Given this list of marker genes NPNT, HIPK2, AXIN1, MIR21, FLCN, GOT1, CITED2, RNF111 (NCBI Gene Id 54778), CITED1, GIPC1, CDKN1C, CDKN2B, ING2, TSC22D1, TGFBR3, FERMT1, ADISSP (NCBI Gene Id 54976), HSP90AB1, EP300, ZEB2, CREBBP, SLC2A10, ITGA8, LRG1, SNW1, STK11, SMAD4, MIR30B, MEN1, THBS1, TWSG1, TGFB1I1, MYOCD, SDCBP, here is a description of the gene set: Any process that activates or increases the frequency, rate or extent of cellular response to transforming growth factor beta stimulus. Human Gene Set: GOBP_POSITIVE_REGULATION_OF_CELLULAR_RESPONSE_TO_TRANSFORMING_GROWTH_FACTOR_BETA_STIMULUS species: Homo sapiens